Given this list of marker genes RIGI, NFKB2, MAP3K14, RELB, ERN1, NFKBIA (NFKB inhibitor alpha), PARP16, CLDN6, TIPARP, TFPI2, BTRC, MAVS, CREBBP, IKBKG, ZC3HAV1, SKP1, GSK3B, IKBKB, PARP10, PARP14, TBK1, EP300, CHUK, CUL1, EIF2AK3, RBX1 (ring-box 1), PARP12, PARP1, here is a description of the gene set: NF-kB signaling and ARTD family members Human Gene Set: WP_NFKB_SIGNALING_AND_ARTD_FAMILY_MEMBERS studied in species Homo sapiens